The following is a description of a gene set: A clathrin-sculpted lipid bilayer membrane-enclosed vesicle after clathrin release and containing monoamines. studied in species Homo sapiens Human Gene Set: GOCC_CLATHRIN_SCULPTED_MONOAMINE_TRANSPORT_VESICLE, and this is the list of marker genes: RAB3A, SYT1, VAMP2, SLC18A1, SLC18A2